The following is a description of a gene set: Human Gene Set: MIR514B_5P studied in species Homo sapiens Genes predicted to be targets of miRBase v22 microRNA hsa-miR-514b-5p in miRDB v6.0 with MirTarget v4 prediction scores > 80 (high confidence targets). from publication Chen Y, Wang X (PMID 31504780), and this is the list of marker genes: ZNF90, PPTC7, LRATD2, BTG3, ZNF264, FBXO45, DVL3, TMEM123, NCOA3, FCF1, FOLR1, MRPL44, PLEKHA3, ZNF680, SAMD8, BCLAF1, PI4K2B, PPP4R3A, UBR4, KCNAB1, VAMP1, ZYG11B, CLDN22, SIPA1L3, CNTNAP2 (NCBI Gene Id 26047), TMEM33, STK40, BRCA2, ITPR2, NFIA, GMFB, SLC26A9, BRWD1, ABL2, RBM39, ZFP69 (NCBI Gene Id 654213), AGXT2, LTBP1, MPZL1, PTGR2, UBE2K, ANGPT2, UACA, MINDY2, ARMC8, GPM6B, TIPRL, MCTP2, SLTM, MTMR4, ARPC5L, EIF2AK1, SIKE1, NUFIP2, LSM2, SEZ6L, SRR, IPCEF1, GPR158, IRF2BP1 (interferon regulatory factor 2 binding protein 1), GASK1B, PLXDC2, KRTAP2-3, KCTD12, INTS5, RABGAP1L, CCSER2, KATNBL1, BRI3, RUNDC3B, MAT2B, HNRNPR, DLX1, ABLIM1, SBSPON, SEPSECS, IGF2BP1, ZNF711, CLIC4, ZNF273, VCPIP1, PDE3B, NDUFA4, PTER (phosphotriesterase related), THPO, RNFT2, KCNQ3, SMAD4, ADAM9, MARCHF3, AP1AR, SKIL, TRAM1, HMBOX1, NBEA, KSR2, PRKAA2, TOB1, SHROOM3, CLEC1A (C-type lectin domain family 1 member A), ZNHIT6, NFYB, HYLS1, TIFA, KLHL20, DBP, RFX3, MAP3K2, RAI14, GABRB3, MET, RASGEF1A, RC3H1, LRBA, POGLUT1, NIPAL4, HEPHL1, UPF2, NECAB1, ZNF730, SYPL1, DAPP1, PHTF2, COMMD4, VGLL3, SYN1, RCN1, ALG13, RNF41, SIRPB1, DNAJC15, GPRIN3, UBE3A, CKAP2, GNG2, RNMT, NCK2, TM6SF1, ATP11B, PRDM16, ANKS1B, COMMD2, TMEM64, TADA2B, TRMT6, PEX12, PTRH2, GPR137B, CCDC47, ACER1, ZNF100, SYTL2, FGF21, ZNF318, ATP6V0A2, SRGAP2, IBTK (inhibitor of Bruton tyrosine kinase), STAMBP, GON7, TRIM37, GPATCH2, SLC30A8, AGO1, KLHL11, CBR4, GXYLT1, ZNF283, RREB1, PPP1R9A, ZBTB20, ZKSCAN2, PTPN4, SLC36A4, BCKDHB (branched chain keto acid dehydrogenase E1 subunit beta), YTHDC2, NAA50, PLEKHH2